Given this list of marker genes TUBB6, MEIS1, HOXA9, FADS1, ECHDC2, HOXA10, SLC16A1, CEACAM8, HOXB2, HOXB5, ARHGEF3, CD52, RUNX1, GNA12, IGHM, GRAMD1B, SEL1L3, SH3TC1, CTNNA1, SUCLG2, IGF2BP2, KLF9, TNS3, EPB41L2, TBL1X, BASP1, SFXN3, DRAM1, NDFIP1, HSPB1, ATN1, here is a description of the gene set: studied in species Homo sapiens from publication Valk PJ, Verhaak RG, Beijen MA, Erpelinck CA, Barjesteh van Waalwijk van Doorn-Khosrovani S, Boer JM, Beverloo HB, Moorhouse MJ, van der Spek PJ, Löwenberg B, Delwel R (PMID 15084694) Human Gene Set: VALK_AML_CLUSTER_15 Top genes from cluster 15 of acute myeloid leukemia (AML) expression profile; 88% of the samples are FAB M1 or M2 subtype, 63% have mutations in CEBPA. BACKGROUND: In patients with acute myeloid leukemia (AML) a combination of methods must be used to classify the disease, make therapeutic decisions, and determine the prognosis. However, this combined approach provides correct therapeutic and prognostic information in only 50 percent of cases. METHODS: We determined the gene-expression profiles in samples of peripheral blood or bone marrow from 285 patients with AML using Affymetrix U133A GeneChips containing approximately 13,000 unique genes or expression-signature tags. Data analyses were carried out with Omniviz, significance analysis of microarrays, and prediction analysis of microarrays software. Statistical analyses were performed to determine the prognostic significance of cases of AML with specific molecular signatures. RESULTS: Unsupervised cluster analyses identified 16 groups of patients with AML on the basis of molecular signatures. We identified the genes that defined these clusters and determined the minimal numbers of genes needed to identify prognostically important clusters with a high degree of accuracy. The clustering was driven by the presence of chromosomal lesions (e.g., t(8;21), t(15;17), and inv(16)), particular genetic mutations (CEBPA), and abnormal oncogene expression (EVI1). We identified several novel clusters, some consisting of specimens with normal karyotypes. A unique cluster with a distinctive gene-expression signature included cases of AML with a poor treatment outcome. CONCLUSIONS: Gene-expression profiling allows a comprehensive classification of AML that includes previously identified genetically defined subgroups and a novel cluster with an adverse prognosis.